Given this list of marker genes CELSR1, KCNK6, ST8SIA3, OTOP1, LY6H, NEUROG3, TFAP2C, CA10, AMIGO2, TFAP2D, IGSF21, SP8, LHX5, LHX8, ISL1, VAT1L, WNT4, PDX1, FAM167A, SLC6A17, SCRT1 (scratch family transcriptional repressor 1), CPLX1, NEUROD2, GATA5, UTF1, BMP4, HOXC8, PTPRT, RAB37, NKX2-1, MAST1, ZNF536, HRH3, DMRT1, RAP1GAP2, PAPPA, WNT3A, HOXD10, FAM43B, COLEC12, DACT2, PAX1, HOXB2, BNC2, HOXB7, CRHR1, CDH1, BCL11A, NPTXR, KCNH1, HOXB5, PLK5, LSR, EVA1A, HOXA9, SYNE3 (spectrin repeat containing nuclear envelope family member 3), CACNA2D2, MAL2, GRIN1, ONECUT3, B3GNT7, SPINT1, HOXC9, SIX6, VGLL2, SFRP1, KCNQ1, KCNS2, PTPRN (protein tyrosine phosphatase receptor type N), RALYL, ALX1, IGFBPL1 (NCBI Gene Id 347252), SULT4A1, SLC38A4, ST8SIA6, FSTL4, PRKCZ, TMEM130, FEV, TFAP2B, IRF5, JHY, SKAP1, KCNA7, POU4F2, NXPH2, VWA2, PRDM16, ECEL1, SIM1, KCTD8, C6orf132, SGPP2 (sphingosine-1-phosphate phosphatase 2), LRRC26, GRIN2B, PTH1R, FOXB2, NPR3, HTR1A, FGF3, IGF2BP1, CNTN2, PAX3, EVX2, DRD2, STMN2, PYY, NLRP6, SORCS3, TNFRSF11A (TNF receptor superfamily member 11a), GJB2, TMEM151A (transmembrane protein 151A), CCKBR, RSPO1, HOXC13, SLC6A5, IL11, PROKR2, CRB3, VSX1, COL13A1, DEGS2, CPNE5, FOXN4, MAL, DMRT3, AJM1, SYT2, LRFN5, RYR2, SLC6A3, SLC12A5, LMX1A, S1PR5, FIBCD1, DLGAP2, ANKRD63, PLXDC1, TNFRSF1B, LEMD1, COL15A1, PGBD5, ALK, LLGL2, GPR37, WNT10A, DBX1, SLC22A3, PGR, GFI1, HCN2, CLSTN2, SIM2, SOWAHB, IKZF3, RXRG, JPH3, NPAS2, POU4F3, FAM89A, HOXB4, TLX3, FEZF2, PAX7, FOXE3, CYP2S1, CCDC92B, CARTPT, GABRG3, TDRP, STBD1, TP73, GABRA5, GJD2, FOXL1, HOXB1, PRXL2B, VAX1, TCERG1L, COBL, HR, NALF2, ADRA2C, TRPC6, PITX1, LRAT, ATP12A, HTR7, VDR, C1QTNF4, KCNK3, DMRT2, SCN5A, OVOL1, SNHG11, FFAR4, UNCX, RASGEF1C, PHF24, CHRNA4 (cholinergic receptor nicotinic alpha 4 subunit), GRIK3, JAG2, FLT3, HES2, OVOL2, GALR3, ALDH1A2, CLDN7, FOXG1, IKZF1, CHAT, SLIT2, TBXT, HOXB8, ALX3, HOXB9, IHH, NPAS1 (NCBI Gene Id 4861), RTN4R, RPRML, CRYBA2, KCNS3, BHLHE23, FGF14, HPCAL4, SLCO4C1, CBLN4, STAC2, ATP2B2, PPM1N, LIN28A, PTF1A, HOXA13, UCN, HS3ST6, SCUBE1 (signal peptide, CUB domain and EGF like domain containing 1), SRCIN1, LAD1, GSX2, MIXL1, C1QL1, DMBX1, TMEM163, SYT12, HOXA11, NEFH (neurofilament heavy chain), MPPED1, PITPNM3, SLC9A2, SHISA6, PENK, RAB11FIP1 (RAB11 family interacting protein 1), WNT1 (NCBI Gene Id 7471), RAB11FIP4, OPRD1, GALNT13, CDX2, SLC30A3, PDGFB, VIPR1, NKX6-1, CRTAC1, CXCL14, SLC17A6, SNAI3, SFRP5, GSX1, ADGRB1, TMEM132E, C12orf56, TBX21, GRM7, PRPH, CNNM1, TBX3, NFATC2, CABP7, CYP26A1, PPP2R2C, MAP3K21, EMX1, NELL1, HCRTR1, SERINC2, ABCG1, SLC7A14, SLC6A20, MSC, TMEM150C, HOXC10, B4GALNT2, TLX1, FGF4, GHSR, HOXB3, IQSEC3, SALL4, BMP6, DOCK8, POU2F3, EPHA8, NKX2-3, BNC1, HOXD9, SOX18, WNT9B, C1QL2, FAM163B, CALCR, CA7, LTBP2, OTP, HCK, DSCAML1, LBX1, CDH8, MESP1, PROK2, FBLL1, EIF4E3, HOXC6, IGF2, DLX3, CPZ, HECW1, SIGIRR, RBFOX3, CIMIP3, KCNQ2, EVX1, LIPG, DPP10, PHLDA2, SKOR1, GPR27, COL14A1, CADM3, RIPK4, SCN4B, SPTBN2, HOXD11, FOXD3, TCF15, SCNN1G, TMEM91, HCN1, here is a description of the gene set: from publication Mikkelsen TS, Ku M, Jaffe DB, Issac B, Lieberman E, Giannoukos G, Alvarez P, Brockman W, Kim TK, Koche RP, Lee W, Mendenhall E, O'Donovan A, Presser A, Russ C, Xie X, Meissner A, Wernig M, Jaenisch R, Nusbaum C, Lander ES, Bernstein BE (PMID 17603471) Human Gene Set: MIKKELSEN_NPC_HCP_WITH_H3K27ME3 We report the application of single-molecule-based sequencing technology for high-throughput profiling of histone modifications in mammalian cells. By obtaining over four billion bases of sequence from chromatin immunoprecipitated DNA, we generated genome-wide chromatin-state maps of mouse embryonic stem cells, neural progenitor cells and embryonic fibroblasts. We find that lysine 4 and lysine 27 trimethylation effectively discriminates genes that are expressed, poised for expression, or stably repressed, and therefore reflect cell state and lineage potential. Lysine 36 trimethylation marks primary coding and non-coding transcripts, facilitating gene annotation. Trimethylation of lysine 9 and lysine 20 is detected at satellite, telomeric and active long-terminal repeats, and can spread into proximal unique sequences. Lysine 4 and lysine 9 trimethylation marks imprinting control regions. Finally, we show that chromatin state can be read in an allele-specific manner by using single nucleotide polymorphisms. This study provides a framework for the application of comprehensive chromatin profiling towards characterization of diverse mammalian cell populations. Genes with high-CpG-density promoters (HCP) bearing histone H3 trimethylation mark at K27 (H3K27me3) in neural progenitor cells (NPC). species: Mus musculus